The following is a description of a gene set: Human Gene Set: GOMF_PROTEIN_PHOSPHORYLATED_AMINO_ACID_BINDING studied in species Homo sapiens Binding to a phosphorylated amino acid residue within a protein., and this is the list of marker genes: SHB, BTRC, SCAF8, GRAP2, MAPK1, YES1, CBLB, ABL1, SAMSN1, PFN1, PIK3R1, SH2D3A, SHF, SFN, SHC1, LCK, YWHAE, SH2D3C, SHD, CRKL, SLA, YWHAB, ZAP70, MAPK3, CBL, PTPN3, SCAF4, PIK3R3, GRB2, FBXW7, SYK, YWHAZ, PCIF1, CRK, FGR, PTPN6 (protein tyrosine phosphatase non-receptor type 6), ABL2, GRAP (NCBI Gene Id 112268188), NCK2, VAV2, PIK3R2, IRS1, HCK, SOCS3, PLCG2, CBLC, PTPN5, SHE, BCAR3, PIN1, LEO1, LDLRAP1, STAP1, SH3BP2, PTPN11, NEDD4, VAV1, RASA1, SHC3